The following is a description of a gene set: Toll like receptors (TLRs) sense microbial products and initiate adaptive immune responses by activating dendritic cells (DCs). Since pathogens may contain several agonists we asked whether different TLRs may synergize in DC activation. We report that in human and mouse DC TLR3 or TLR4 potently synergize with TLR7, TLR8 or TLR9 in the induction of selected cytokine genes. Upon synergistic stimulation, IL-12, IL-23 and Delta-4 are induced at levels 50-100 fold higher than those induced by optimal concentrations of single agonists, leading to enhanced and sustained TH1 polarizing capacity. Using microarray analysis we show that only 1.5% of the transcripts induced by single TLR agonists are synergistically regulated by combinations of TLR4 and TLR8 agonists. These results identify a combinatorial code by which DCs discriminate pathogens and provide (suggest) a rationale to design adjuvants for TH1 responses. Series_overall_design: 3 untreated, 3 treated with LPS at 2h, 3 treated with LPS at 8h, 3 treated with R848 at 2h, 3 treated with R848 at 8h, 3 treated with LPS + R848 at 2h, 3 treated with LPS + R848 at 8h studied in species Homo sapiens Human Gene Set: GSE2706_R848_VS_R848_AND_LPS_2H_STIM_DC_UP from publication Napolitani G, Rinaldi A, Bertoni F, Sallusto F, Lanzavecchia A (PMID 15995707) Genes up-regulated in comparison of dendritic cells (DC) stimulated with R848 at 2 h versus DCs stimulated with LPS (TLR4 agonist) and R848 for 2 h., and this is the list of marker genes: DUSP18, GUCA1B, APOL4, ATP5MC2, SLC26A3, PLEKHF1, ARFIP2, SEC13, PIAS3, FFAR2, DDR1, MRPS11, ID1, TTC5, ENSG00000274253, TACC3, POLE3, SERPINA6, ZNF195, AFG3L1P, EFHD1, FAM167B, RAPGEF4-AS1, ZNF608, TAS2R50, TRG-AS1 (NCBI Gene Id 100506776), TIGD5, THBS1, DEFB126, FPR2, CNKSR1, KLHDC3, ID3, TRAT1, NEO1, MED1, HARBI1 (NCBI Gene Id 283254), NUFIP2, FBXL12, LINC00102, CYLC2, ZC3H15, EPO, MRPL38, RAD54B, POLR2J, NBEAL2, SLC27A6, NOP16, SP3P, DKKL1, CFAP45 (cilia and flagella associated protein 45), SPSB2, TRIM65, NUS1P3, ELOF1, RNF32-DT, LINC01622, PABIR1, C10orf67 (chromosome 10 open reading frame 67), CYP2S1, ZNF574, PHLDB2, PIP4P1, IGSF8, FBXW8, USP10, CLDN2, DRAXIN, SRSF4, OTUB1, LTBP4, IRX5, APOBEC2, TGM3, KCTD21, ZNF331, SLC16A1-AS1, PRKCZ, ZNF134, ERF, PKD2L1, ATXN2L, SCARNA2, THAP2, ADNP2, MAD2L1BP (MAD2L1 binding protein), FGF7, TKTL1, SERPINA7, POFUT2, GPR19, EIF4ENIF1, GET3, TMC1, DCUN1D2, RNF26, ZNF620, SIGIRR, FHL3, CIDEA, MOV10, PON3, PCDHGB5, IGFN1, DVL3, DARS2, CCDC33, TLCD1, STAG3L1, AP1G2, LILRP2, HOXD4, DLEU1, ARMC10, ZBTB7B (NCBI Gene Id 51043), RTP5, CSF1R, LINC01854, PTCD3, C15orf62, SERTAD3, RPL39L, TSSK6, PHAF1, SDSL, TRMT2A, ZSCAN22, ZNF780B, PCDH7, ARL2, DAGLB, C16orf87, ZNF835, ZNF3, REXO1, ERBB4, NCOA2, HERC3, ODF2L, SMYD3, C1orf56, SNAI3, GH2, BORCS6, SDCBP2-AS1, MARVELD3, WNT10B, JRK, VNN2, CCDC66, FAM238C, ZNF791, AATF, FCSK, FAM120AOS, ZNF701, EPCIP, ABCC13, NPHP1, MLF2, SNAI3-AS1, LHX1, POLR2J2, MYORG, SIGMAR1, FAM118B, BTBD19, PDCD7, TBC1D25, MYCBPAP, TAS2R38, ZNF451 (zinc finger protein 451), ZNF606, TIMM50, SCAMP2, FREM2, NDUFAF7, IMP3 (IMP U3 small nucleolar ribonucleoprotein 3), BRF2, KCTD4 (potassium channel tetramerization domain containing 4), CT83, TEPSIN, RPL13P5, C2CD4C, ANKRD17, TAF7L